The following is a description of a gene set: species: Homo sapiens Human Gene Set: MIR6794_5P from publication Chen Y, Wang X (PMID 31504780) Genes predicted to be targets of miRBase v22 microRNA hsa-miR-6794-5p in miRDB v6.0 with MirTarget v4 prediction scores > 80 (high confidence targets)., and this is the list of marker genes: RAG1, STXBP4, CHD6, TRAF4, NCAPH2, TGFBI, CBX5, SPRY4, LARP1, PPP2R2D, USP54, SRF, ERVFRD-1, EFNB1, ME1, NUP50, SFXN3, ZNF395, PTPRJ, ZBTB20, ASAH1, UBAP2L, PDX1, KALRN, ELP5, NOVA2, SRSF2, EPN1, HOXB3, BCL9, PCM1, LPGAT1, AP3B1, NECTIN1, ALDH7A1, MAN1A2, ZNRF2, DEDD, ACOX1, MAMDC2, ARSK, HGF, RAD51B, PHLPP1, KAZN, ONECUT2, STC1, REEP1, CPM, LDB1, TRNP1, PXYLP1, RAB14, CTNND1, PPP2R1A, XBP1, CSDE1 (cold shock domain containing E1), SUMO2, RALGPS1, SLC22A23, CADM1, FBXL20, RAB2B, APPL1, LZTS1, DOCK3, RASL11B, APOLD1, ESR1, GPR137, EPB41L1, IL17D, RLBP1, FAM222B, MVB12B, PTPRS, DAPP1, KLHL13, SLC12A6, IL18BP, PRUNE1, ATF7